The following is a description of a gene set: Abnormal skin adnexa morphology species: Homo sapiens An abnormality of the skin adnexa (skin appendages), which are specialized skin structures located within the dermis and focally within the subcutaneous fatty tissue, comprising three histologically distinct structures: (1) the pilosebaceous unit (hair follicle and sebaceous glands); (2) the eccrine sweat glands; and (3) the apocrine glands. Human Gene Set: HP_ABNORMAL_SKIN_ADNEXA_MORPHOLOGY, and this is the list of marker genes: CHD2, FRMD4A, STAMBP, CSGALNACT1, TBC1D20, GLI1, PIGS, NSRP1, APC2, VPS37D, KRT6A, PROKR2, ZNF407, RNF125, WNT10A, CSTB, TMEM218, DNAJC30, LRP2, POGLUT1, GDF6, DMXL2, DPAGT1, HPGD, MDM2, VPS33A, MGP, ATP7A, GLI2, PORCN, C4B, POT1, HPS5, TFE3, EPS8L3, COX5A, ABL1, FOXP3, LMNB1, RHOBTB2, TCF12, NFIX, SV2A, SHROOM4, TMEM270, PLCD1, RPS10, YARS2, SH2B1, TGM5, LTV1, LRMDA, SGSH, GJB2, AHDC1, ATL1, SMARCC2, BMPER, PRKACB, MECP2, OTX2, ERCC8, PLAA, RPL5, KDF1, CHD6, BCR, ODC1, ALX4, PSMB8, ITGB6, TREX1, IGHG1, ACTB, SEC31A, SOX4, DEPDC5, WNK1, SLC6A9, KCNK4, FGF3, FLII, FGF10, C3orf52, CAMK2B, ARHGAP31, RUSC2, CLDN1, LZTR1, ARID1A, PYCR1, SETD1B, LYST, TELO2, LMNA, ARL13B, NFIB, KDSR, ARID1B, FBXL4, BCL11B, RRAS2, ASXL2, SNX10, CANT1, IGF2 (insulin like growth factor 2), SNRPE, FHL1, WBP4, SHOC2, ALDOA, ERCC3, KITLG, KRT10, EDEM3, TSR2, CAMTA1, INPP5E, ITGB4, POC1A, NFKBIA, CTSC, HRAS, KDM5C, CTU2, WNT5A, PIBF1 (NCBI Gene Id 10464), HECW2, AHSG, EFNB1, NXN, ADAM17, IL2RA, AXL, XRCC4, ATP6V1E1, KRT5 (NCBI Gene Id 3852), MAP3K1, KCNJ8, HHAT, JARID2, RETREG1 (NCBI Gene Id 96119), KISS1R (NCBI Gene Id 9291), MAFB, WAC, HPS4, ETS1, TAF6, MGMT, IRX5, INSR, DCLRE1C, GORAB, SMO, TWIST2, CLCN6, B3GLCT, ZNF699, KDM6A, SLC39A4, PDGFRB, SPEN, B9D1, ZIC3, MSH4, RNU4ATAC, VEGFC, SLC27A4, ARX, ZEB2, SVBP, ERCC2, BBS10, FAM111B, KIAA0753, RBL2, MEG3 (NCBI Gene Id 55384), CENPE, PADI3, GPR101, MAP3K7, BCKDK, PIK3CD, PIGQ, HLA-DRA, SDR9C7, NAF1, KATNB1, IL1RAPL1, PRKACA, BHLHA9, TOGARAM1, BLOC1S3, NEK1, ACVR1, HERC1, SLC35D1, DNAJC21, KEAP1, DYNC2LI1, CDK13, MT-ND1, TTC5, MESD, SLC6A1, ZC4H2, GLB1, FOS, PIGN, TBX3, LTBP3, DDX6, PRPS1, WDR73, UBE3A, UBAP2L, PLEC, FEZF1 (NCBI Gene Id 392779), CDKN1C, PGAP2, MEGF8, DPH2, CSPP1, MT-ND4, CEP152 (NCBI Gene Id 23701), IRF5, TUBGCP2, SLC45A1, COL3A1, PRDM16, FOSL2, ECEL1, KLF13, DSP, FOCAD, RPL35A (ribosomal protein L35a), RAD21, FLT4, DCAF17, PROP1, HR (NCBI Gene Id 55806), TCTN3, PLOD3, ADA, SLCO2A1, PACS2, PIGF, LAMC2, INPPL1, MYCN, ZNF292, ZMPSTE24, PPP1R13L, POLR1D, NPM1, CDON, FGD1, ACTL6B, ARSB, CEBPE, CERS3, BMP15, AXIN2, CHRNA7, CDSN, NEPRO, SIK1, DYM, CYB5A, PIEZO1, PEPD, MT-CO3, TCF4, CHD8, SOX10, DSC3 (desmocollin 3), RET, STING1, SOX9, EPG5, KIF15, TNFAIP3, SOX5, TCHH, APC, MID1, SOS1, CCDC8, UBE4B, RAG2, PHGDH, ABCA2, VPS35L, PRDM13, NUP107, CCDC32, RPA1, RAB27A, TOMM7, RAB7A, TRMT1, NDN, B3GALT6, ERCC5, MT-CO1, MED13, RAB18, CUL7, MAP1B, BANK1, SMARCD1, CARD14, DPH1, SKIC3, PIGO, GNA14 (G protein subunit alpha 14), ORC6, TARS1, DPM1, TERT, ABCA5 (NCBI Gene Id 55514), GJC2, CCDC47, GRIP1, BMP1, NOTCH1, WASHC5, SLC4A10, FBXO28, FOXE1, FLNB, KLK11, CARS1, PCGF2, PRR12, EMC1, ALDH18A1, COL11A2, NEXMIF, STAG2, PACS1, HS2ST1, SUMF1, GNS, ATP6V1A, PIK3C2A, ASPM, XPC, AEBP1, ATR, GABRD, CLCN3, WDR81, RPL18, LAMA3 (laminin subunit alpha 3), PTEN, HESX1, GTF2I, TMCO1, TNFSF4, NPR2, EDA, FLCN, PWRN1, SOS2, CDC42, DSG1, TMEM67, IQSEC2, ADAMTS2, SMARCA4, MITF, CEP290, NRCAM, MAP2K2, CBY1, ERI1, ERMARD, NECTIN4, TRMT10A, C4A, FBN1, COL7A1, HSPA9, UBR7, CDH1, KCNH1, MED13L, PEX19, TERF2IP (TERF2 interacting protein), COLEC11, PPP1R15B, ASL, TAFAZZIN, SRA1, TBX2, ACTG1, TLK2, SLC1A4, CUL4B, FAS, KIT, BRCA1, KRAS, GJA5, KATNIP, CDK10, RAP1GDS1, SNRPN, FGFRL1, GTF2IRD2, PPP1R21, DHX30, CNBP, SLURP1, WRAP53, RPS19, EFEMP1, SATB1 (NCBI Gene Id 6304), NSD2, FGFR3, ADARB1, FLNA, B9D2 (B9 domain containing 2), WRN, GNA11, MKKS, NEUROG1, SMARCA2, BMPR1B, SYT1, RALA, RPS27, ARHGEF2, KIFBP, ZNRF3, GDF3, TAC3, KRT9, DLL4, CDKL5, RFC2, PIGY, H3-3A, STUB1, PEX1, KRT17, MLH1, DLX3, ITGA3, DDX3X, CPLANE1, CLCN7, ESAM, ASH1L, MEN1, CFAP418, SCNM1, MBTPS2, LSS, PGAP1, HNF1B, STAT4, ALG3, CYP11B1, PROK2, SMARCAD1, HCCS, METTL27, RSPO4, SUZ12 (SUZ12 polycomb repressive complex 2 subunit), EXT1, TMEM147, RPL10, MAPKAPK5, SIAH1, MAGEL2, CKAP2L, ZNF141, TINF2, DSC2, PEX2, ZIC2, CCDC28B, PRIM1, P4HA2, RPS24, CAPN15, NBN, PTCH1, SLC9A6, CD151, LMX1B (NCBI Gene Id 4010), RAI1, MYOF, CYFIP2, BCOR, ACAN, IRAK1, EOGT, VAMP7, ZNF341, KRT81, TSPEAR, NECTIN1, GPC3, SETD5, KLHL24, BBS9, ELMO2, AAGAB, USP9X, SLC45A2, PXK, SOX11, EIF4A2, CAMKMT, CNOT3, KCNA1, SON, SEC23A, EDNRA, PEX6, IL17F, CTSK (NCBI Gene Id 1513), MAP3K20, ATP6V1B2, TP53, EGFR, SLC12A6, KMT2B, BNC1, PPP2R5D, PIGK, WDR26, FDFT1, FOXL2, ANOS1, MARS1, SHOX, OTUD6B, SLC26A2, USB1, NEU1 (neuraminidase 1), HLA-B, GNRH1, AIMP2, KRT25, ARID2, STX1A, COG7, PPARG, DPYSL5, RPS28, LRP1, LARP7, KCNMA1, NOP10, PHYH, ITGAM, RPL21, DPP9 (dipeptidyl peptidase 9), NCF1 (NCBI Gene Id 653844), PWAR1, HSD3B2 (NCBI Gene Id 3284), FOXA2, CASK, ATRIP, THOC6, IL36RN, MT-TF, MYO5A, PSMC1, FKRP, GTPBP2, TGM1, ATP6V0A2, MAPRE2, CTNNB1, SMOC1, MAPK8IP3, SLC35A2, HID1 (NCBI Gene Id 80791), TFAP2A, RAB34, SNX14, IL2RG, SCARF2 (NCBI Gene Id 91179), DSG4, CCNK, ZSWIM7, CEP57, TIMM50, TRIM8, BANF1, OGT, ALK, HDAC4, EBF3, SMC3, HRURF, GSN (gelsolin), MRPS22, NIPBL, NHLH2 (NCBI Gene Id 90888), KCNAB2, CDIN1 (NCBI Gene Id 84529), WWOX, LUZP1, BRD4, LIPN, ERCC4 (NCBI Gene Id 7509), ADAMTS3, SMAD4, SLC6A17, MRAS, MLXIPL, KIF11, ATM, MT-CO2 (NCBI Gene Id 4513), FZD6, PDCD6IP, RNF113A, NAA80, TRPS1, CAMK2A, CBS, FGF5, BCS1L, STAG1, EDARADD, PLAGL1, CTNND1, SMARCE1, SNORD115-1, CCDC141, MAN1B1, KMT2C, DSG2, CRIPT, WNT10B, NANS, RMRP, IFT27, PURA, MMP1, RLIM, COL14A1, TBC1D24, HGSNAT, MSTO1, ITPR2, SLC30A2, RERE, SKIC2, NCAPG2, PIGB, FCGR2B, DPM2, FGF8, MKRN3, RBCK1, TLR7, POP1, UFC1, HGD, CD96, IL17RC, THUMPD1, AFG2B, MTHFS, CNP, RAC3, MEOX1, WDR45 (NCBI Gene Id 11152), RAB3GAP2, MT-TL1, ZPR1, OTUD5, TRAC, GON7, SEMA3E, RBPJ, GABBR1, HYMAI, CHST3, KRT85, CASP2, PAX3, DHX37, NSUN2, NR0B1, COG4, PTDSS1, SOX18, TRIO, HPS3, CST6, SETD2, NHP2, TMEM216, FMR1, UROS, ORC1, SLC25A12, MAF, MTOR (NCBI Gene Id 2476), TUBGCP6, GJA8, COL17A1, PNKP, PIK3R1, TRPM3, GRM7, ANGPT1, DICER1, ANKRD11, IKBKG, PAK2, DHCR7, RSPO1, CAV1, CR2, AP3B1, ACSL4, COL1A2, LEMD3, AIP, RAF1, EVC2, GAN, ANKRD17, SMCHD1, LTBP1, SCN2A, POFUT1, PRKCD, CWF19L1, FREM2, TBX4, RPL26, BMP2, SCO2, TMEM138, LRPPRC, IGF1, DNA2, VPS13B, ZNF423, LHCGR, DPH5, PPP2R1A, HDAC8, TP63, ASXL1, SRCAP, PAPSS2, CRELD1, KCNN3 (NCBI Gene Id 95947), CAST, CNTNAP2, EDN3, MEF2C, TOPORS, CDK5, NBAS, MC1R, LETM1, POR, TMPRSS6, AHI1, MSH2, RPL27, TRAF6, ATP1A3, CSTA, POLR1A, VDR, ARL3, GJB3, POLD3, FAT4, CNOT2, VPS51, UQCC2, MAPK1, KRT86, TUBB, RPS20, TCOF1, GABRA3, DTNBP1, TAF4, KDM1A (lysine demethylase 1A), NOG, RPS15A, TECPR2, C1GALT1C1, HOXC13, CLMP, TERC, KREMEN1, SRD5A2, WARS1, TRIM32 (NCBI Gene Id 3971), AUTS2, ALG11, COL18A1, CDC45, DRG1, MAB21L1, BMP4 (bone morphogenetic protein 4), NUS1, SRY (NCBI Gene Id 6995), HOXA13, CDKN2B, PGM2L1, COPB1, EDA2R, CYP4F22, B4GALT7, H4C9, WASHC4, SPTBN1, RPS26, TTI2, POU1F1, LPAR6, FRAS1, ADNP, CDKN2A, H4C11, HLA-DQB1, STN1, PCDHGC4, ACD, AKT1, SLC30A9, NELFA, POLA1, ALOXE3, NMNAT1, ALG9, BTK, UBE2L3, ZMYND11, SPECC1L, PIGA, CTLA4, EBP, UROD, SPIDR, AIFM1, SCAPER, CHN1, PDE6D, HLA-C, PSMC3, POMC, TRPV3, ROR2, TNFRSF1B, NOTCH3, DOLK, SCN9A, ZNF462, H3-3B, PTPN11, ATAD3A, ALDH6A1, TTC7A, PIGW, TSC2, COG5, HLA-DRB1, DMPK, CEP295 (NCBI Gene Id 85459), TASP1, SETBP1, CHD1, FGFR2, PRKAR1A, DSTYK (dual serine/threonine and tyrosine protein kinase), SPRY4, SCN4A, TUFT1, RAG1, SASH1, FGFR1, GTF2E2, ALG12, ATP2A2, ATRX, GATAD2B, ABCC9, ATP10A, NTRK1, PDE11A, SKI, CEP104, MSX1 (msh homeobox 1), ATP1A2, TACR3, KIAA0319L, XPA, FAR1, SLITRK1, FGF17, ANTXR1, CYP19A1, FAM149B1, NUP85, TMEM94, PRKD1, IL10, RPL15, MADD, TSPAN7 (NCBI Gene Id 7102), AFF3 (ALF transcription elongation factor 3), POGZ, AFG2A (NCBI Gene Id 170576), SPP1, TRAF7, CREBBP, CPLX1, EXOC8, LAS1L, ALMS1, HECTD4, WT1, GRIN1, CCBE1, GATA4, CPT2, WDR35, CENPT, TGM3, MAD1L1, LHX4, POLR3A, EXOSC2, AP3D1, SALL4, TAF1, TTC8, ARMC9, ASPRV1, GPC4, SULT2B1, IARS2, POMP, HERC2, EED, IDUA, TGDS, TOE1, DDX59, PAH, GATA1, FLI1, BBS2, HPS1, PHIP, SPRTN, HBA1, RHOA, HYOU1, HBA2, CLEC7A, MMP23B, NF1, DKC1, SMARCB1, PDCD1, ITGA6, TALDO1, MAN2C1, CTC1, BRCC3, PIGV, GLI3, KCNK9, CHRNG, MPLKIP, FERMT1, SPINK5, RBM10, MACROH2A1, SPRED2, PDPN, OCRL, RBBP8, CDH2, IFIH1, CERT1, CDH11, RNF2, JAZF1, UGP2, KISS1, ACER3, IFT122, TRAPPC9, PARN, GRHL2, MED25, AQP5, SMC1A, DUSP6, NUP188, LIG4, VPS37A (NCBI Gene Id 23687), NPAP1, CHD7, MCCC2, EZH2, ANTXR2 (NCBI Gene Id 118429), MVK, TRAIP, CDK4, FAM20C, RPGRIP1L, TBL2 (NCBI Gene Id 27203), PREPL, NDUFA6, SCLT1, BLK, ZNF711, TMEM237, ACTG2, WNT7A, BSCL2, STAT3, FRMPD4, USP8, LAMTOR2, DLX4, FBXO11, DEAF1, FOXP2, SMS, POLR1B, RASA2, PLK4, BCAS3, GNPTAB, MASP1 (MBL associated serine protease 1), SLC1A3, HLCS, TYMS, ALX1, LZTFL1, OBSL1, BPTF, CEP19, CACNA1C, BUD23 (NCBI Gene Id 84118), GNRHR, PTPN22, SLC29A3, MOGS, SUOX, CWC27 (NCBI Gene Id 10283), NRAS, TCTN1, KNSTRN, KRT6B, ACBD6, RECQL, HMGA2, CCDC22, RPS7, KRT83, SCUBE3, MT-TQ, MBD5 (methyl-CpG binding domain protein 5), ACVRL1, BBS7, MT-ND5, CHSY1, ESR1 (NCBI Gene Id 2099), RUNX2, SMPD4, CASR, LIFR, BGN, NPHP1, CACNA1A, UBE2A (NCBI Gene Id 7319), CSF1R, ELN, HNRNPU, PPOX, JUP, LIMK1, SIN3B, TYR, PPP2R3C, ASXL3, TET2, CEP41, SLC5A6, ZNF469, ADAMTSL2, RNF13, MN1, VARS1, MED12L, DDB1, CC2D2A, SIM1, DDB2, PYCR2, MMP14, NUDT2, PDE4D, TRRAP, KAT6A (lysine acetyltransferase 6A), NDST1, FGF9, XYLT1, PKP1, GTF2H5, ZBTB18, EXT2, ECM1, TNIP1, ENG, SLC24A5, FIG4 (FIG4 phosphoinositide 5-phosphatase), AFF4, STT3A, TBCK, HSPG2, IL11RA, GNAO1, ZIC1, CASZ1, AP2M1, LAMB3, MED12 (NCBI Gene Id 9968), PIGU, CYB5R3, GMPPA, EDAR, NSMF, CBL, GDF11, AP1S3, SUCLA2, WNT4, UBR1, ABCA12, HPD, FCGR3B, EIF4H, ZMYM2, LORICRIN, PEX7, RNU12, TMEM222, C18orf32, NSD1, ROBO1, CACNA1G, FSHB, KAT5, PRKCZ, PAX9, SLC25A24, TMEM231, RALGAPA1, RPS29, FKBP6, WDR19, ARL6, TRAF3IP2, MTAP, FZD2, PRKG2, IDS, AP3B2 (NCBI Gene Id 8120), FSHR, FTL, NR2F1, NDUFAF6, EP300, DPYD, PQBP1, SHANK3, MT-TH, DNASE1, RAC1, SNORD116-1, NOVA2, HNRNPH2, SUPT16H, TCIRG1, KIAA0586, MAP2K1, EMC10, SYNGAP1, GPRASP2, KDM4B, LRP4, APCDD1, IL17RA, KRT74, KIF1A, PIGL, MKS1, RIPK4, MT-TS2, OAT, BBS12, HEPHL1, ERCC6 (ERCC excision repair 6, chromatin remodeling factor), WLS, CAVIN1, SOST, SLC35C1, ZFX, BAP1, ABHD5, CPOX, CLP1, DST, MGAT2, STK11, PUS7, DCLRE1B, FUCA1, UBE3B, SCN1B, BTNL2, MMP2, FILIP1, NFKB2, PSMC3IP, SLC24A4, KIF26A, RRAS, PRMT7, HPS6, INTU, PRRX1, CDC42BPB, BBS5, KRT16, TCTN2, PSENEN, IGF1R, DLK1, IFNG, PPM1B, ALX3, SET, GTF2IRD1, VAC14, NEK9 (NCBI Gene Id 91754), IFT74, WDPCP, HLA-DQA1, ST14, UGDH, KRT1, ESCO2, EDNRB, NKX6-2, HFE, RPS17, PERP, ALDH3A2, EHMT1, STXBP1, GNAS (GNAS complex locus), RTEL1, FUT8, IFT52, RPS23, BLOC1S5, SCN1A (sodium voltage-gated channel alpha subunit 1), RPL31, PRDM5, IRF6 (interferon regulatory factor 6), COX7B, AHCY, SLC9A7, BLM, HNRNPR, IFT43, PLAG1, SOX6, RPL9, TSC1, MEIS2, NSDHL, ZFPM2, NAGLU, TENT5A (NCBI Gene Id 55603), POLR3H, MAN2B1, APOE, BTD, ABCA1, AP1B1, KAT6B, NR5A1, H4C5, PHF8 (PHD finger protein 8), DVL1, H6PD, AARS1, HPDL, RPL8, KRT71, PTPRF, AGPAT2, PHF6, CSNK2A1, PNPLA1, KLLN, RAP1B, SNAI2, BCORL1, KMT2D, CYP17A1 (NCBI Gene Id 1586), POLR1C, STIM1, CDH23, KRT14, HNRNPH1, PPP1CB, TNFSF11, PUM1, PLXNA1, SLC3A1, COLEC10, ENPP1, GUSB (NCBI Gene Id 2990), NDUFA12 (NADH:ubiquinone oxidoreductase subunit A12), TAT, HYLS1, RNU4-2, SEC23B, CDK19, BICRA (NCBI Gene Id 29998), CTCF, TRPM4, CD28, SMARCAL1, PUF60, FTO, LMBRD2, OCA2, ZSWIM6, ATP2B1, GNE, DENND5A, RAB3GAP1 (NCBI Gene Id 338380), PCNT, MED27, BBS4, RPS6KA3, H1-4, SRD5A3, HIVEP2, MAB21L2, CTBP1 (NCBI Gene Id 1487), APTX, TTI1, GJB6, FOXN1, ANGPT2, IFT140, INTS1, SF3B1, SPOP, PNPLA6 (NCBI Gene Id 10908), NAA10, RPL35, SPRED1, LIPH, FRA10AC1, PI4KA, EVC, PSMB10, MT-TW, HEATR3, GDF5, BRAF, SATB2, COG6, AMMECR1, SAT1, MLPH, SMARCD2, WBP11, SOX3, DOCK6, FOXC2, KIF7, GJA1, PIGG, SREBF1, HS6ST1, TRNT1, SIN3A, IHH, KCNE5, TBCD, KCTD1, EIF5A, TRAPPC10, DPF2, RTL1, ADAT3, GAD1, SF3B4, TFAP2B, ADA2, PCSK1, BBS1, AIRE, GNB2, PLAAT3, TYRP1, PITX1, NLRP1, HUWE1, SDCCAG8, SHMT2, PPM1D, RIN2, ABCD1, MANF, MT-ND6, UQCRFS1, NIPAL4 (NCBI Gene Id 348938), DCT, COL11A1, NOTCH2, CAMK2G, ERLIN2, NFKB1, MCTP2, LMNB2, CDH3, BBIP1, SLC7A7 (solute carrier family 7 member 7), KANSL1 (KAT8 regulatory NSL complex subunit 1), SZT2, STRADA, UMPS, NEUROD2, CTNS, USP48, AASS, LHB, UBA2, RIT1, YY1, PUS1, GJB4, NDUFB11, ANAPC1, OFD1, HNRNPK, DOCK7, MYO18B, KNL1, PGAP3, BRF1, ALOX12B, SLC2A1, WDR11, ASCC3, ARMC5, IL7R, CHD5, AR, RECQL4, KMT5B, FREM1, CRKL, ZBTB20, DNMT3A, PSMD12, PLCB4, IPO8, SLC17A5, U2AF2, ECE1, MYH3, TBL1XR1, RBM28, TBX15, HTRA1, TWIST1, TUBGCP4, IFT172, XYLT2, CLIP2, MTX2, FOXP1, BAZ1B, MPV17, CEP120, C12orf57, NR3C1, CAPRIN1, FBXO31, B3GAT3, PIGP, CHMP1A, DVL3, SLC25A22, KANK2, RPL11, IL6ST, CIT, KMT2A (NCBI Gene Id 79951), SUFU, SLC32A1